The following is a description of a gene set: studied in species Homo sapiens Human Gene Set: GOBP_XENOPHAGY The selective degradation of intracellular pathogen or some part of an intracellular pathogen (e.g. viral capsid) by macroautophagy., and this is the list of marker genes: RIPK2, RNF31, OPTN, TBK1, LRSAM1, IRGM, RNF213, CALCOCO2, MAPK3, ATG16L1, NOD1, LGALS8 (NCBI Gene Id 3964)